Given this list of marker genes 1700013H16Rik, Gcg, Clec7a, Plek, Fcgr2b, C1qb, Xist, Cd53, Defb10, Ccl7, Elavl2 (ELAV like RNA binding protein 1), Cd36, Ms4a6d, 0610033M10Rik, Kidins220, Arsb, Cxcl12, Igfbp4, Thbd, Arid3b, Cemip, Uba1y, Mmp12, Fcgr3, Il6, Cxcl5, Ccl9, Gpnmb, A330076H08Rik, Angptl2, here is a description of the gene set: Division of spermatogonial stem cells produces daughter cells that either maintain their stem cell identity or undergo differentiation to form mature sperm. The Sertoli cell, the only somatic cell within seminiferous tubules, provides the stem cell niche through physical support and expression of surface proteins and soluble factors. Here we show that the Ets related molecule (ERM) is expressed exclusively within Sertoli cells in the testis and is required for spermatogonial stem cell self-renewal. Mice with targeted disruption of ERM have a loss of maintenance of spermatogonial stem cell self-renewal without a block in normal spermatogenic differentiation and thus have progressive germ-cell depletion and a Sertoli-cell-only syndrome. Microarray analysis of primary Sertoli cells from ERM-deficient mice showed alterations in secreted factors known to regulate the haematopoietic stem cell niche. These results identify a new function for the Ets family transcription factors in spermatogenesis and provide an example of transcriptional control of a vertebrate stem cell niche. Genes down-regulated in Sertoli cells from both 4 and 10 week old ETV5 knockout mice. studied in species Mus musculus from publication Chen C, Ouyang W, Grigura V, Zhou Q, Carnes K, Lim H, Zhao GQ, Arber S, Kurpios N, Murphy TL, Cheng AM, Hassell JA, Chandrashekar V, Hofmann MC, Hess RA, Murphy KM (PMID 16107850) Mouse Gene Set: CHEN_ETV5_TARGETS_SERTOLI